The following is a description of a gene set: Human Gene Set: GOBP_LNCRNA_MEDIATED_POST_TRANSCRIPTIONAL_GENE_SILENCING A post-transcriptional gene silencing pathway in which regulatory long noncoding RNAs (lncRNAs) elicit silencing of specific target genes, often miRNAs or mRNAs. species: Homo sapiens, and this is the list of marker genes: TUSC8, OIP5-AS1, SMAD5-AS1, MALAT1, DNM3OS, HOTTIP, XIST, NEAT1, ELAVL1, STAU1, PTENP1-AS